The following is a description of a gene set: Positive Elastic Net coefficient component of Forty-eight genes properly discriminating severe from mild evolution of COVID-19 pneumonia in the validation cohort (Elastic Net-penalized linear model). species: Homo sapiens from publication Armignacco R, Carlier N, Jouinot A, Birtolo MF, de Murat D, Tubach F, Hausfater P, Simon T, Gorochov G, Pourcher V, Beurton A, Goulet H, Manivet P, Bertherat J, Assié G, COVIDeF group (PMID 38772950) COVID-19 is associated with heterogeneous outcome. Early identification of a severe progression of the disease is essential to properly manage the patients and improve their outcome. Biomarkers reflecting an increased inflammatory response, as well as individual features including advanced age, male gender, and pre-existing comorbidities, are risk factors of severe COVID-19. Yet, these features show limited accuracy for outcome prediction. The aim was to evaluate the prognostic value of whole blood transcriptome at an early stage of the disease. Blood transcriptome of patients with mild pneumonia was profiled. Patients with subsequent severe COVID-19 were compared to those with favourable outcome, and a molecular predictor based on gene expression was built. Unsupervised classification discriminated patients who would later develop a COVID-19-related severe pneumonia. The corresponding gene expression signature reflected the immune response to the viral infection dominated by a prominent type I interferon, with IFI27 among the most over-expressed genes. A 48-genes transcriptome signature predicting the risk of severe COVID-19 was built on a training cohort, then validated on an external independent cohort, showing an accuracy of 81% for predicting severe outcome. These results identify an early transcriptome signature of severe COVID-19 pneumonia, with a possible relevance to improve COVID-19 patient management. Human Gene Set: ARMIGNACCO_SEVERE_COVID19_RISK_EN_POS, and this is the list of marker genes: REEP2, CYP19A1, VNN1, TIMM10, CCL3, DEPP1, IFI6, CNGA4, PPARG, CREB3L1, NAALADL2, CD70, HSPB9, PCSK9, DSP, LINC01762, LINC01300, GALM, CA12, C3AR1 (complement C3a receptor 1)